The following is a description of a gene set: Human Gene Set: MODULE_521 T-cell proliferation genes. studied in species Homo sapiens, and this is the list of marker genes: NAMPT, CCKBR, IL3, DDX11, S1PR2, TIMP1, TNFSF4, EGF, HBEGF, CD3E, IL6, FGF7, CTF1, CXCL5, VIPR1, CD86, FGG, SSR1, FOSL1, DHPS, FLT1, LIF, NRP1, IGF1, PTN, CDK2, CSF1 (colony stimulating factor 1), ADRA1D, GRN, SLAMF1, CIAO1, VEGFC, CSF3, FGB, EDN1, STIM1